The following is a description of a gene set: Human Gene Set: MIR1251_5P Genes predicted to be targets of miRBase v22 microRNA hsa-miR-1251-5p in miRDB v6.0 with MirTarget v4 prediction scores > 80 (high confidence targets). studied in species Homo sapiens from publication Chen Y, Wang X (PMID 31504780), and this is the list of marker genes: CCDC62, MRPL17, ELP1, NOTCH2NLA (NCBI Gene Id 388677), UBXN2B (UBX domain protein 2B), ZSCAN20, FMO1, TAOK1, TMEM181, ITCH, KPNA3, FAM98A, MIA3, HS6ST3, NLGN2, TAF1A, ASB15, UTP11, APBB2, MECP2, QSER1, REPIN1, FGA, TBCD, SETD3, WDR6, ZNF398